The following is a description of a gene set: species: Homo sapiens PI3K gamma (PI3KG) is a heterodimer consisting of a p110 catalytic subunit associated with a regulatory p101 or p84 subunit. PI3KG is most highly expressed in neutrophils, where the p101 form predominates (approximately 95%). G beta:gamma recruits PI3KG to the plasma membrane, both activating PI3KG and providing access to its substrate PIP2, which is converted to PIP3. Reactome Pathway: G beta:gamma signalling through PI3Kgamma part of: G-protein beta:gamma signalling, and this is the list of marker genes: GNG5, AKT3, GNG4, GNB1, GNB2, GNG11, GNG10, AKT2, GNG2, GNB3, GNG8, GNGT1, GNG3, GNB5, GNG12, PDPK1, PIK3R6, GNGT2, PIK3R5, RHOA, GNG13, AKT1, PIK3CG, GNB4, GNG7